The following is a description of a gene set: Human Gene Set: GOBP_ANTIGEN_PROCESSING_AND_PRESENTATION_OF_ENDOGENOUS_PEPTIDE_ANTIGEN studied in species Homo sapiens The process in which an antigen-presenting cell expresses a peptide antigen of endogenous origin on its cell surface in association with an MHC protein complex. The peptide is typically a fragment of a larger endogenous protein which has been degraded within the cell., and this is the list of marker genes: HLA-DRB1, RAET1E, AZGP1 (NCBI Gene Id 90053), B2M, HLA-E, ULBP2, IDE, HLA-A, ULBP3, HLA-C, HLA-H, RAET1L, TAP2, ERAP2, HLA-DRA, TAPBP, RAET1G, TAP1, ERAP1, HFE, ULBP1 (NCBI Gene Id 80329), HLA-B, HLA-G, HLA-F